Given this list of marker genes APEX1, MAGEB4, PELI1, FAM8A1, CRLF3, UBXN2B, KDM1A, CCDC82, ABCB10, SIAH1, DSTYK, SAP30BP, GOLGA5, RLF, CDKN1B, CASP2, EIF2B2, HOXB4, PTTG1IP, ZNF639, OGA, TMEM223, RNF111, UBR1, CDK5RAP1, TMEM60, TPRG1L, TIMM22, ZEB1, STX5, FBXO38, SLFN13, PARG, FBXO32, TRIT1, CNBP, PTGES3, NME6, PSMD11, CRIM1, GIMAP4, ARMCX4, BTBD1, TM9SF3, TTI2, SUPT16H, SYCP3, RNF19A, NANP, ARL14EP, CNDP2, CDC37L1, YTHDC1, PHF20L1, USP9X, MMADHC, CAB39, SPSB3, C15orf40, FBXO8 (NCBI Gene Id 26269), SLC38A1, NSMCE4A, TRIM23, CNOT6, SSR1, TRIM59, STK39, CFL2, TAX1BP1, SRRD (NCBI Gene Id 402055), DUSP10, NTNG1, TRMT1L (NCBI Gene Id 81627), RMND5A, ZNF326, POLDIP3 (NCBI Gene Id 84271), CFL1, POLG2 (NCBI Gene Id 11232), SENP1, BSN, SLFN12L, AKIRIN2, CD2BP2, CREBRF, SCN7A, CBFB, TSPYL4, TP53INP1, VCF1, TLR4, MSRA, PLEK2 (pleckstrin 2), RBM15B, SRRM1, ERI1, PCNP, MADD (MAP kinase activating death domain), UBP1, USP7, GSK3B, MORF4L1, RNF135, VTI1B, TNNT2, C2orf49, CSNK1D, BRD8, SMAD5, PDE7A, NRBF2 (NCBI Gene Id 91155), HP1BP3, ZNF394, FEZ2, MYB, SIKE1, IL11, ANAPC7, KLHDC2, MAPK8, MXD4, NFYB, IL16, TEX2, LRRK1, RPL13, EMC3, WTAP, SMC3, RPL27, REPS1, PTGR3, SMIM7, CHAD, CCN1, TDP2, MED23, TNFSF10, PHACTR1, SELENOT, KLHL42, GNA15, HNRNPC, RABGEF1, SECISBP2L, TPP2, KBTBD2, CCNL2, ATG16L1, ANKFY1, FKBPL, SDHAF1, TBRG1, ATP5F1D, RHEBL1, CALN1 (NCBI Gene Id 83698), GPATCH8, PIP4K2A, HBP1, EVA1C, SASS6, HAUS3 (HAUS augmin like complex subunit 3), MAP4K4, SLC30A9 (NCBI Gene Id 10463), GNPDA2, DLG1, ALKBH4, SYNRG, HLA-G, NMNAT1, USP39, RNF181, MXD3, ATP6V1E1, HIGD1B, TDRP, ETF1, WASF2, HS2ST1, ZNF689, ARL8B, PAPOLG, ATG12, ING3, GBE1, SPARCL1, NR1H4, KANK3, CDK16, SECISBP2, CPSF7, AVL9, SSX2IP, AAK1, KDM3A, CNOT2, ZYG11B, NFYC, MTREX, CCDC198, ZNF292, here is a description of the gene set: Genes down-regulated in T reg: untreated ADORA2A knockout versus wildtype treated by ZM 241385. Human Gene Set: GSE34006_A2AR_KO_VS_A2AR_AGONIST_TREATED_TREG_DN studied in species Homo sapiens The adenosine 2A receptor (A2AR) is expressed on regulatory T cells (Tregs), but the functional significance is currently unknown. We compared the gene expression between wild-type (WT) and A2AR knockout (KO) Tregs and between WT Tregs treated with vehicle or a selective A2AR agonist. from publication Kinsey GR, Huang L, Jaworska K, Khutsishvili K, Becker DA, Ye H, Lobo PI, Okusa MD (PMID 22835488)